The following is a description of a gene set: Mouse Gene Set: REACTOME_RHO_GTPASES_ACTIVATE_RHOTEKIN_AND_RHOPHILINS RHO GTPases Activate Rhotekin and Rhophilins species: Mus musculus, and this is the list of marker genes: Rhpn2, Rhoa, Tax1bp3, Rhpn1, Lin7b, Rtkn